The following is a description of a gene set: species: Mus musculus Mouse Gene Set: GOCC_SPINE_APPARATUS A specialization of the endomembrane system found in some classes of dendritic spines consisting of two or more closely apposed lamellae with interspersed electron dense material. The endomembrane component is continuous with the smooth endoplasmic reticulum., and this is the list of marker genes: Fmr1, Chrna7, Oprd1, Ppp1r9b, Ppfia1, Clstn1, Aplp2, Oprm1, Synpo